Given this list of marker genes HYAL4, CHSY1, NCAN, BGN, GLB1, CHST15, CHST13, CHST14, HEXB, IDUA, CHSY3, CSGALNACT1, HYAL3, CHST7, CHST12, CSPG5, DSEL, CHPF, DCN, CHST3, CHPF2, GUSB, CHST9, ARSB, GLB1L3, CSGALNACT2, GLB1L, DSE, VCAN, GLB1L2, HEXA, CHST11 (NCBI Gene Id 55807), CSPG4, BCAN, HYAL1 (NCBI Gene Id 3373), UST, IDS, here is a description of the gene set: Chondroitin sulfate (CS) is a sulfated glycosaminoglycan (GAG). CS chains are unbranched polysaccharides of varying length containing two alternating monosaccharides: D-glucuronic acid (GlcA) and N-acetyl-D-galactosamine (GalNAc). The chains are usually attached to proteins forming a proteoglycan. CS chains are an important structural component of cartilage due to it's ability to withstand compression. Free CS, produced by hydrolysis of cartilage, is also a widely used dietary supplement for osteoarthritis. When some of the GlcA residues are epimerized into L-iduronic acid (IdoA) the resulting disaccharide is then referred to as dermatan sulfate (DS) (Silbert & Sugumaran 2002). DS is the most predominant GAG in skin but is also found in blood vessels, heart valves, tendons, and the lungs. It may play roles in cardiovascular disease, tumorigenesis, infection, wound repair and fibrosis (Trowbridge & Gallo 2002). part of: Glycosaminoglycan metabolism Reactome Pathway: Chondroitin sulfate/dermatan sulfate metabolism species: Homo sapiens